Given this list of marker genes TNFSF18, TNFRSF18, BIRC2, PSMB7, TNFRSF4, TNFRSF12A, TNFSF9, BTRC, UBB, EDARADD, PSMA1, PSMB4, CD70, PSMD13, LTBR, ADRM1, PSMA3, TNFRSF14, TNFSF11, LTB, CHUK, PSMD1, TNFRSF25, UBE2M, PSMC4, FBXW11, PSMD2 (NCBI Gene Id 5708), SEM1, NFKB2, PSMD12, PSMC2, TNFRSF13C (NCBI Gene Id 115650), PSMD14, PSMD7, TNFRSF8, TRAF2, TNFRSF17, PSMA4, PSMB2, LTA (NCBI Gene Id 4049), EDA2R, TNFSF8, EDA, PSMB3, PSMB1, TNFRSF1B, TRAF3, PSMA7 (NCBI Gene Id 5688), UBA3, TNFSF14, TNFRSF11B, EDAR (ectodysplasin A receptor), TNFSF15, TNFSF6, PSMA5, RPS27A, UBC, PSMD3, CD27, TNFSF13, TNF, TNFSF4 (NCBI Gene Id 7292), TNFRSF1A, PSMB5, TNFSF13B, BIRC3, PSMD6, TNFRSF13B, PSMC1, PSMB6, RELB, MAP3K14, PSMC5, PSMC6, PSMA2, CUL1, PSMA6, CD40LG, PSMC3, PSMD11, TNFSF12, TNFRSF9, PSMD8, TNFRSF11A, CD40, UBA52, TNFRSF6B, SKP1, here is a description of the gene set: Reactome Pathway: TNFR2 non-canonical NF-kB pathway studied in species Homo sapiens part of: Cytokine Signaling in Immune system Tumor necrosis factor-alpha (TNFA) exerts a wide range of biological effects through TNF receptor 1 (TNFR1) and TNF receptor 2 (TNFR2). Under normal physiological conditions TNFR2 exhibits more restricted expression, being found on certain subpopulation of immune cells and few other cell types (Grell et al. 1995 ). TNFR1 mediated signalling pathways have been very well characterized but, TNFR2 has been much less well studied. TNFR1 upon activation by TNFA activates apoptosis through two pathways, involving the adaptor proteins TNFR1-associated death domain (TRADD) and fas-associated death domain (FADD). In contrast, TNFR2 signalling especially in highly activated T cells, induces cell survival pathways that can result in cell proliferation by activating transcription factor NF-kB (nuclear factor-kB) via the alternative non-canonical route. TNFR2 signalling seems to play an important role, in particular for the function of regulatory T cells. It offers protective roles in several disorders, including autoimmune diseases, heart diseases, demyelinating and neurodegenerative disorders and infectious diseases (Faustman & Davis 2010).<br>Activation of the non-canonical pathway by TNFR2 is mediated through a signalling complex that includes TNF receptor-associated factor (TRAF2 and TRAF3), cellular inhibitor of apoptosis (cIAP1 and cIAP2), and NF-kB-inducing kinase (NIK). In this complex TRAF3 functions as a bridging factor between the cIAP1/2:TRAF2 complex and NIK. In resting cells cIAP1/2 in the signalling complex mediates K48-linked polyubiquitination of NIK and subsequent proteasomal degradation making NIK levels invisible. Upon TNFR2 stimulation, TRAF2 is recruited to the intracellular TRAF binding motif and this also indirectly recruits TRAF1 and cIAP1/2, as well as TRAF3 and NIK which are already bound to TRAF2 in unstimulated cells. TRAF2 mediates K63-linked ubiquitination of cIAP1/2 and this in turn mediates cIAP dependent K48-linked ubiquitination of TRAF3 leading to the proteasome-dependent degradation of the latter. As TRAF3 is degraded, NIK can no longer interact with TRAF1/2:cIAP complex. As a result NIK concentration in the cytosol increases and NIK gets stabilised and activated. Activated NIK phosphorylates IKKalpha, which in turn phosphorylates p100 (NFkB2) subunit. Phosphorylated p100 is also ubiquitinated by the SCF-beta-TRCP ubiquitin ligase complex and is subsequently processed by the proteaseome to p52, which is a transcriptionally competent NF-kB subunit in conjunction with RelB.